The following is a description of a gene set: Catalysis of the reaction: nucleoside triphosphate + RNA(n) = diphosphate + RNA(n+1); the synthesis of RNA from ribonucleotide triphosphates in the presence of a nucleic acid template. Human Gene Set: GOMF_RNA_POLYMERASE_ACTIVITY species: Homo sapiens, and this is the list of marker genes: POLR1D, POLR2C, POLR2E, POLR1B, TERT, POLR2J2, PRIM1, POLR2F, POLR3K, POLR2H, POLR2L, POLR2J, POLR2I, POLR1H, POLR3C, MED21, CRCP, POLR1A, POLR3B, POLR3A, DDX21, POLR1C, PRIMPOL, POLR2J3, POLRMT, POLR2B, PRIM2, POLR2A, TRNT1, MED20, POLR3H, UVSSA, POLR2K, POLR3G, POLR3F